Given this list of marker genes MYH11, UCHL1, SNCA, HNRNPK, MAGEL2, ZFX, ATP7A (ATPase copper transporting alpha), VPS13C, OCA2, NDN, PARK7, MPEG1, EIF2AK2, RRM2B, PODXL, TWNK, TYMP, HTRA2 (HtrA serine peptidase 2), MAP3K7, SYNJ1, ACTG2, RAD21, PRKN, SON, MGAT2, PINK1, POLG, LRRK2, SNRPN, AFF4, SLC25A4, RRM1, TMEM70, DNAJC6 (NCBI Gene Id 9829), POLG2, here is a description of the gene set: species: Homo sapiens Gastroparesis Decreased strength of the muscle layer of stomach, which leads to a decreased ability to empty the contents of the stomach despite the absence of obstruction. Human Gene Set: HP_GASTROPARESIS